The following is a description of a gene set: MAPK targets/ Nuclear events mediated by MAP kinases Human Gene Set: REACTOME_MAPK_TARGETS_NUCLEAR_EVENTS_MEDIATED_BY_MAP_KINASES studied in species Homo sapiens, and this is the list of marker genes: MAPK3, ELK1, MAPK10 (mitogen-activated protein kinase 10), PPP2R1B, JUN, MAPK7, MEF2C, PPP2R1A, ATF2, MEF2A, PPP2CB (protein phosphatase 2 catalytic subunit beta), DUSP3, MAPK9, RPS6KA2, MAPK14, PPP2CA, MAPK1, ATF1, PPP2R5D, MAPKAPK2, VRK3, MAPK11, DUSP7, DUSP6, RPS6KA5, FOS, CREB1, RPS6KA3, DUSP4, MAPK8, RPS6KA1 (NCBI Gene Id 6195)